The following is a description of a gene set: Mouse Gene Set: BERENJENO_TRANSFORMED_BY_RHOA_FOREVER_DN species: Mus musculus from publication Berenjeno IM, Núñez F, Bustelo XR (PMID 17213802) We have used microarray technology to identify the transcriptional targets of Rho subfamily guanosine 5'-triphosphate (GTP)ases in NIH3T3 cells. This analysis indicated that murine fibroblasts transformed by these proteins show similar transcriptomal profiles. Functional annotation of the regulated genes indicate that Rho subfamily GTPases target a wide spectrum of functions, although loci encoding proteins linked to proliferation and DNA synthesis/transcription are upregulated preferentially. Rho proteins promote four main networks of interacting proteins nucleated around E2F, c-Jun, c-Myc and p53. Of those, E2F, c-Jun and c-Myc are essential for the maintenance of cell transformation. Inhibition of Rock, one of the main Rho GTPase targets, leads to small changes in the transcriptome of Rho-transformed cells. Rock inhibition decreases c-myc gene expression without affecting the E2F and c-Jun pathways. Loss-of-function studies demonstrate that c-Myc is important for the blockage of cell-contact inhibition rather than for promoting the proliferation of Rho-transformed cells. However, c-Myc overexpression does not bypass the inhibition of cell transformation induced by Rock blockage, indicating that c-Myc is essential, but not sufficient, for Rock-dependent transformation. These results reveal the complexity of the genetic program orchestrated by the Rho subfamily and pinpoint protein networks that mediate different aspects of the malignant phenotype of Rho-transformed cells. Genes down-regulated in NIH3T3 cells (fibroblasts) transfrormed by expression of constitutively active (Q63L) form of RHOA off plasmid vector; their expression did NOT reverted completely after treatment with Y27632, an inhibitor of ROCK proteins., and this is the list of marker genes: Npnt, Cxcl1, Akap12 (A kinase anchor protein 12), Ccdc80, Gja1, Mtmr10, Haspin, Nop58, Hbegf, Tom1l1, Epha2, Ankrd1 (NCBI Gene Id 12907), Chd1, Anxa3, Ereg, Bnc1, Tnk2, Ect2, Mgp, Phlda1, Flnb, Amot, Cavin2 (caveolae associated 2), Ptgs2, Plaur, F2r, Ier3, Lrrfip1, Postn, Hsph1